The following is a description of a gene set: from publication Chen Y, Wang X (PMID 31504780) Human Gene Set: MIR18A_5P_MIR18B_5P Genes predicted to be targets of miRBase v22 microRNA hsa-miR-18a-5p, hsa-miR-18b-5p in miRDB v6.0 with MirTarget v4 prediction scores > 80 (high confidence targets). studied in species Homo sapiens, and this is the list of marker genes: DICER1, IQSEC3, XYLT2, ZNF704, ZNF99, ZBTB4, RNF145, NEDD4, NEDD9, KLHL20, TRAPPC8, MEF2C, BBX, ZCCHC24, RUNX1, PDE4D, CCR2, EPB41L1, KCNH7, XYLT1, TRIB2, AGFG1, SMAP2, ZCCHC3 (NCBI Gene Id 85364), ITGA2, AEBP2, ADD3, KCMF1, TMEM248 (transmembrane protein 248), CEMIP2, DPPA3, PNLIPRP3, HSF5, HEATR5A, PHF19, PHC3, TAOK1, DIRAS2, TBC1D9B, KLF6, CA13, CREBL2, PARD6B, DIP2C, MAPK4, ERI1, KCNS2, SUCO, CDK19, GOSR2, GIGYF1, ACSL3, PTCHD1, PIAS3, ZBTB44, ESR1, TWF1, LACTB2, ZFP62, FAM3C, NUFIP2 (nuclear FMR1 interacting protein 2), RBBP8, CCDC88A, SIX3, TRPC4, RAB5A, KPNA6 (karyopherin subunit alpha 6), GCLC, HMGCS1, OLFML2B, VPS13A, TNFAIP3, FRS2, BRWD3, GPR158, NR1I2, CTDSPL, TOR1B, RORA, ZNF365, ZBTB47, BTG3, FBXL3, HIF1A (hypoxia inducible factor 1 subunit alpha), CA12, RAB5C, ZNF367, ATM, NAA50, ATL2, SYNM, ATXN1, SH3BP4, MAP7D1, GLRB, FRYL, CCN2, YBX3 (Y-box binding protein 3), CAD, ESCO2, FCHSD2, IRF2, SMAD2, KCNA1, PNISR, PTGFRN, SORBS2, HMBOX1, MYLK, KDM2A, MAP3K1, SOX6, GIT2, PSD3, ZBTB20, RABGAP1 (NCBI Gene Id 23637), PRSS12, FAM9B, MBOAT2, PATJ, TMEM170B, KCNJ2, FER, YPEL5, TRIOBP